Given this list of marker genes Gpx1, Alox15, Gpx2, Gpx4, Ptgs2, Alox8, here is a description of the gene set: species: Mus musculus electronically inferred by orthology from the curated human pathway Reactome Pathway: Synthesis of 15-eicosatetraenoic acid derivatives part of: Arachidonate metabolism This event has been computationally inferred from an event that has been demonstrated in another species.<p>The inference is based on the homology mapping from PANTHER. Briefly, reactions for which all involved PhysicalEntities (in input, output and catalyst) have a mapped orthologue/paralogue (for complexes at least 75% of components must have a mapping) are inferred to the other species.